The following is a description of a gene set: Understanding the molecular underpinnings of cancer is of critical importance to the development of targeted intervention strategies. Identification of such targets, however, is notoriously difficult and unpredictable. Malignant cell transformation requires the cooperation of a few oncogenic mutations that cause substantial reorganization of many cell features and induce complex changes in gene expression patterns. Genes critical to this multifaceted cellular phenotype have therefore only been identified after signalling pathway analysis or on an ad hoc basis. Our observations that cell transformation by cooperating oncogenic lesions depends on synergistic modulation of downstream signalling circuitry suggest that malignant transformation is a highly cooperative process, involving synergy at multiple levels of regulation, including gene expression. Here we show that a large proportion of genes controlled synergistically by loss-of-function p53 and Ras activation are critical to the malignant state of murine and human colon cells. Notably, 14 out of 24 'cooperation response genes' were found to contribute to tumour formation in gene perturbation experiments. In contrast, only 1 in 14 perturbations of the genes responding in a non-synergistic manner had a similar effect. Synergistic control of gene expression by oncogenic mutations thus emerges as an underlying key to malignancy, and provides an attractive rationale for identifying intervention targets in gene networks downstream of oncogenic gain- and loss-of-function mutations. from publication McMurray HR, Sampson ER, Compitello G, Kinsey C, Newman L, Smith B, Chen SR, Klebanov L, Salzman P, Yakovlev A, Land H (PMID 18500333) species: Mus musculus Down-regulated 'cooperation response genes': responded synergystically to the combination of mutant TP53 and HRAS in YAMC cells (colon). Mouse Gene Set: MCMURRAY_TP53_HRAS_COOPERATION_RESPONSE_DN, and this is the list of marker genes: Zfp385a (zinc finger protein 385A), Abat, Tnfrsf18, Id2, Hey2, Scn3b, Unc45b, Notch3, Plxdc2, Mpzl2, Fas, Mcam, Tex15, Cd55, Jag2, Id4, Abca1, Rasl11a, Prkd1, Rprm, Sfrp2, Mpp7, Rab40b, Rai2, Sema3d, Satb1, Dusp15, Mtus1, Rb1, Perp, Cpz, Dgka, Ms4a10, Dixdc1, Mmp15, Dapk1, Elavl2, Cers4, Col9a3, Garnl3, Sbsn, Dffb, Prkg1, Hoxc13, Bex1, Ckmt1, Sbk1, Pard6g, Ldhb, Pitx2, Fhod3 (formin homology 2 domain containing 3), Slc27a3 (NCBI Gene Id 26568), Atp8a1 (NCBI Gene Id 11980), Stmn4, Gca, Nbea, Pltp (NCBI Gene Id 18830), Wnt9a, Ephb2, Espn, Fgf18, Bbs7, Pmaip1, Man2b1 (NCBI Gene Id 17159), Nectin4, Igfbp2, Arhgap24